The following is a description of a gene set: An abnormality of the fovea centralis, the central area of the macula that mediates central, high resolution vision and contains the largest concentration of cone cells in the retina. Human Gene Set: HP_ABNORMAL_FOVEAL_MORPHOLOGY studied in species Homo sapiens Abnormal foveal morphology, and this is the list of marker genes: MFRP, RS1, HPS4, AP3D1, RDH5, MC1R (NCBI Gene Id 4157), TYR, ATF6, ABCA4, NEU1, SLC24A5, PRPH2, LRP5, OAT, PRR12, CTNNA1 (catenin alpha 1), RPGRIP1, OCA2, CFAP418, FZD5, RPGR, IDS, GDF6, WT1, RBP4, BLOC1S3, SLC45A2, SLC25A19, CACNA1F, GDF3, TLCD3B, PDE6C, DCT, TULP1, PROM1, CNGB3 (cyclic nucleotide gated channel subunit beta 3), MTSS2, CNGA3, FOXC1, IKBKG, TRIM44, FZD4, RLBP1, OFD1, GNAT2, RHO, CFHR3, GPR143, APOE, ELOVL4 (NCBI Gene Id 94678), PAX6, ITPR1, RPE65, HMCN1, PDE6H, HPS5, IMPG1, HPS6 (HPS6 biogenesis of lysosomal organelles complex 2 subunit 3), PDE6G, BLOC1S5, RAB28, UGP2, CFHR1, SLC38A8